The following is a description of a gene set: Mid airway progenitor species: Homo sapiens Human Gene Set: HE_LIM_SUN_FETAL_LUNG_C1_MID_AIRWAY_PROGENITOR_CELL from publication He P, Lim K, Sun D, Pett JP, Jeng Q, Polanski K, Dong Z, Bolt L, Richardson L, Mamanova L, Dabrowska M, Wilbrey-Clark A, Madissoon E, Tuong ZK, Dann E, Suo C, Goh I, Yoshida M, Nikolić MZ, Janes SM, He X, Barker RA, Teichmann SA, Marioni JC, Meyer KB, Rawlins EL (PMID 36493756), and this is the list of marker genes: RP1, CLDN10, THSD4, ELAPOR1, NTN1, CYTL1, NIBAN1, CDH10, SMOC2, FRMD3, MTTP, GRHL1, CALD1, PALMD, CDH2, COL6A2 (NCBI Gene Id 1292)